Given this list of marker genes TXNDC15, KRTCAP2, CAV1 (caveolin 1), KCNH1, SLC44A1 (NCBI Gene Id 63942), here is a description of the gene set: Human Gene Set: ANDERSON_BLOOD_CN54GP140_ADJUVANTED_WITH_GLA_AF_AGE_18_45YO_LOW_IGM_RESPONDERS_6HY_1DY_UP species: Homo sapiens Systems biology approaches have recently provided new insights into the mechanisms of action of human vaccines and adjuvants. Here, we investigated early transcriptional signatures induced in whole blood of healthy subjects following vaccination with a recombinant HIV-1 envelope glycoprotein subunit CN54gp140 adjuvanted with the TLR4 agonist glucopyranosyl lipid adjuvant-aqueous formulation (GLA-AF) and correlated signatures to CN54gp140-specific serum antibody responses. Fourteen healthy volunteers aged 18-45 years were immunized intramuscularly three times at 1-month intervals and whole blood samples were collected at baseline, 6 h, and 1, 3, and 7 days post first immunization. Subtle changes in the transcriptomic profiles were observed following immunization, ranging from over 300 differentially expressed genes (DEGs) at day 1 to nearly 100 DEGs at day 7 following immunization. Functional pathway analysis revealed blood transcription modules (BTMs) related to general cell cycle activation, and innate immune cell activation at early time points, as well as BTMs related to T cells and B cell activation at the later time points post-immunization. Diverse CN54gp140-specific serum antibody responses of the subjects enabled their categorization into high or low responders, at early ( < 1 month) and late (up to 6 months) time points post vaccination. BTM analyses revealed repression of modules enriched in NK cells, and the mitochondrial electron chain, in individuals with high or sustained antigen-specific antibody responses. However, low responders showed an enhancement of BTMs associated with enrichment in myeloid cells and monocytes as well as integrin cell surface interactions. Flow cytometry analysis of peripheral blood mononuclear cells obtained from the subjects revealed an enhanced frequency of CD56<sup>dim</sup> NK cells in the majority of vaccines 14 days after vaccination as compared with the baseline. These results emphasize the utility of a systems biology approach to enhance our understanding on the mechanisms of action of TLR4 adjuvanted human vaccines. Genes up-regulated in blood 6hr/1DY vs 0hr in adults (18-45) (low IgM responders) after exposure to CN54gp140 adjuvanted with GLA-AF, time point 6H/1DY combined (identical signature), administered i.m. from publication Anderson J, Olafsdottir TA, Kratochvil S, McKay PF, Östensson M, Persson J, Shattock RJ, Harandi AM (PMID 29535712)